The following is a description of a gene set: studied in species Homo sapiens part of: Loss of function of MECP2 in Rett syndrome Reactome Pathway: Loss of phosphorylation of MECP2 at T308 Missense mutations of methyl-CpG-binding protein 2 (MECP2) in the vicinity of its threonine T308 phosphorylation site can negatively affect the ability of MECP2 to be phosphorylated at T308 in response to neuronal membrane depolarization (neuronal activity)., and this is the list of marker genes: MECP2, PRKACA, CAMK4, CALM1